Given this list of marker genes GRM1, NPY2R, NPY, NPY5R, GRID2, SYT4, PENK, GRID1, NPPA, here is a description of the gene set: studied in species Homo sapiens Human Gene Set: GOBP_SYNAPTIC_SIGNALING_VIA_NEUROPEPTIDE Cell-cell signaling to or from a synapse, mediated by a peptide.